The following is a description of a gene set: Human Gene Set: GSE27786_LSK_VS_CD8_TCELL_DN from publication Konuma T, Nakamura S, Miyagi S, Negishi M, Chiba T, Oguro H, Yuan J, Mochizuki-Kashio M, Ichikawa H, Miyoshi H, Vidal M, Iwama A (PMID 21540074) species: Homo sapiens Genes down-regulatd in comparison of LSK versus CD8 T cells. Each fraction of mouse hematopoietic cells was purified by cell sorting from bone marrow of 8-week-old C57BL/6 mice, and its gene expression was analyzed., and this is the list of marker genes: FBXL12, CEP164, HOPX, RPL31, DZIP1, PTRH1, SESN3, CNKSR2, HM13, EFR3A, PPIA, GPC6, PSENEN, SERPINC1, RPL23, NDUFB10, USP24, RBM48, GPR37, LEPROTL1, ENO1, VAMP4, WASHC2A, GPN3, RASL11B, IKBKB, RALGAPB, ERRFI1, HADHB (hydroxyacyl-CoA dehydrogenase trifunctional multienzyme complex subunit beta, NCBI Gene Id 3032), KLRG1, RDM1, MINDY3, PI4KA, TNFRSF18, ARPC2, NUDT9, KLF7, SRI, EHD3, EDF1, PRDX5, CFAP91, ACER1, AP3M2, CRNKL1, RRAD, TSPYL4, PRRT1, TTLL11, PTCH1, ROCK1 (Rho associated coiled-coil containing protein kinase 1), PDE1A, PSMA2, MRPS24, SH3GLB1, SMARCD2, ESYT1, HSPA8, EAPP, KLF15, GPR63, ANKRD12, RPL30, SNF8, KIF12, GPR15, VWA3A, KIDINS220, OXSM, TMEM202, RAP2B, PPP1CC, REXO2, TNFAIP1, GLRX2, FLNA, SFMBT2, NAGPA, DLX3, LENG9, MPZL2 (NCBI Gene Id 95160), AKR1B1, LRCH3, ZPR1, MBP, COX4I1, CAMK2D, IL9R, MON2, LAPTM5, GNMT, TPRA1, MCMBP, MPP1, TOMM7, SHLD1, UFM1, C10orf120, LTK, PNKD, UBXN11, RNF19A, EIF3E, COMMD6 (NCBI Gene Id 170622), RASAL3, ITGA4, AQR, ITSN2 (NCBI Gene Id 6454), RPA1, MC1R, WRNIP1, ARHGAP30, MRAP2, PPM1B, PSMB10, CAMK1D, RGCC, SUN2, TIGD2, STAT4 (NCBI Gene Id 6775), UBALD2, ITGA1, SLC30A1, MTURN, PGLYRP1, FAM177A1, PTPRCAP, TMEM179B, CAB39, ACTR2, RAB24, DPY19L1, ESCO1, KLF3, EHD1, NFRKB, RPL34, RECK, FAM117B, SRA1, RETREG3 (reticulophagy regulator family member 3), ANO10, AMELX, PRSS37, FOXK1, CACNG4, ATP5F1E, GABRR2, AEBP2, ECSIT, ZBP1, SLFN13, PPP1CA, GPER1, COX16, OLFML3, ANKRD13D, SAMD8, NDUFA13, CCNL2, GPR65, SLCO5A1, CCN1, TMEM25, MRPL23, SNAPC3, SLC37A3, THAP7, RLF, DRC1, AIP, SYT7, PTPRC, DERL2, WDR26, SEMA4D, ABI1, SURF1, NAA60, KCNAB2 (potassium voltage-gated channel subfamily A regulatory beta subunit 2), TRIR, USP34, DLGAP4, RHOG, MED11, CPEB4, PANK4, SCP2, NEMF (NCBI Gene Id 9147), BRK1, CRHR1, DDX47, C8B (complement C8 beta chain), CARMIL2, EEF1G, MDM2, PIP5K1A, NDRG3, CLDN10, AP1S2